Given this list of marker genes SSH3, DMTN, RDX, PRKCD, MAPRE1, CAPZA3, GSN, MTPN, VIL1, ASB2, LMOD2, SPTA1, CAPZA2, ADD3, CAPZA1, LMOD3, SNCA, MKKS, PFN1 (profilin 1), CAPZB, SSH1, EML2, AVIL, STMN1, KANK4, STMN2, ARFGEF1, VILL, ADD2, TMSB4X, CARMIL2, TRIOBP, CDH5, SVIL, CLIP3, CRACD, KANK1, LMOD1, SLIT2, CAPG, CARMIL1, DYRK1A, KANK2, SSH2, CYRIB, TMOD4, SPTAN1, FLII, MYADM, ARHGEF7, TUBB4A, PFN2, TMOD3, ADD1, SCIN, MIR214, SPTBN4, KANK3, TWF1, TMOD2 (tropomodulin 2), SPTB (NCBI Gene Id 6710), HIP1R, TBCD, BBS4, CFL1 (NCBI Gene Id 1072), INPP5J, FKBP4, TMOD1, SPTBN1, SPTBN2, EPS8, TWF2, SPTBN5, MAP2, WASHC2C, here is a description of the gene set: Any process that stops, prevents, or reduces the frequency, rate or extent of the process of creating protein polymers. species: Homo sapiens Human Gene Set: GOBP_NEGATIVE_REGULATION_OF_PROTEIN_POLYMERIZATION